Given this list of marker genes MPPE1, TDP2, ATP13A2, PEPD, PPM1N, ADCY10, GALNT1, ME1, NUDT7, MGAT1, PRIMPOL, XPNPEP3, B4GALT1, DCP2, ABL2, IMPA1, FEN1, NPEPL1, PCK2 (NCBI Gene Id 5106), LARGE2, ARG2, XXYLT1, ARG1, MTPAP, PCK1, PIM1, GALNT4, PRKACA, HMGCL, SOD2, XPNPEP1, MGAT5B, DYRK2, ATP2C1 (NCBI Gene Id 612), WRN, ENDOU, MRE11, PPEF2, MPPED2, ADPRM, GYG1, NUDT16, POMGNT1, GALNT3, B4GALT7, XYLT2, IDI1 (NCBI Gene Id 3422), NUDT3, MGAT2, PPM1B, CDIPT, EXTL2, MGAT5, GALNT2, PPEF1, PPM1A, ADCY2, ABO, PAPOLA, PPM1K, ABL1, EXD2, PPM1M, NEK4, TSSK3, FAM20C, LAP3, LARGE1 (NCBI Gene Id 9215), NUDT8, here is a description of the gene set: Human Gene Set: GOMF_MANGANESE_ION_BINDING Binding to a manganese ion (Mn). species: Homo sapiens